Given this list of marker genes ZNRD2-DT, ZNF257, CCDC144A, MELTF, HOXA10, SIGLEC9, GNAQ, TFPI, ZSCAN16-AS1, GUSBP14, ECT2, CRNDE, LDC1P (NCBI Gene Id 651413), CHRNA3, IFT81, FCGR2C, ZBTB44, TIMM23B (translocase of inner mitochondrial membrane 23 homolog B), CCNJ, HPSE2, ADAMTS1, MDM4, CYP2F1, CUBN, SEM1, ETV5, PALLD, KIR2DL4, AEBP1, NEK2, DNAJC9, TNFRSF21, GPR4, CTTN, PTGDR2, NEIL3, ANP32A, CD79B, TCF7, COL6A3, HOXA7, GLI4, PCGF5, COL7A1, DST, HNRNPK, MARCKSL1, GARIN3, ITIH3, PELI2, SLC22A18AS, KIAA1217, RNFT2, RUBCNL, KMT2A, XCL1, SP4, LINC01686, DDX5, LAPTM4A, ENSG00000228919, ENSG00000257545, TTTY10, FAM118A, SOX4, CENPV, OPRPN, CORIN (corin, serine peptidase), CEP97, ANKRD36BP2, HOXA9, MSI2, SPCS2, SLC22A7, H2BW2, DLAT, IL4, DBN1, SIMC1P1, POMP, BATF3, RUFY2, TFF3, ANKRD20A11P, SORT1, INHBC, DNAI3, H3-3B, CHSY1, LRRN4, PPEF1, EVC2, BCL11B, OSBPL5, CDC25A, CCDC83, CALHM5, SH2D1A, KDM5D, FBLL1, RPS4Y1, LRRN1, TXLNGY, AKR1C3, KIF23, CBX5, SMPD3, QSER1, PDE10A, EPB41L2, ALDH2, ZNF169, ADGRB2, RGMA, ELAVL4, SYCE1 (NCBI Gene Id 93426), BMS1P20, SLC44A5, CD300A, FZD1, PRKY, PDZD9, PTGS1, MBD6, TRDMT1, LINC00205, CMC2, GPRIN1, KRTAP5-2, GGA1, HMGB3, LYST, DDX3Y, GJC1, PLCH1, CD1D, GLIPR1L1, GALNT2, CHD9, GXYLT2, RTN4, EIF1AY, LDLRAD3, GALNT7, PCMT1, WFDC3, ATP6AP1L (NCBI Gene Id 92270), CDK6, GNA15, UBE2J1, HHIP, LMO2, INPP5B, PKN2, PHLPP1, ITPRID2, CDSN, SLC7A3 (solute carrier family 7 member 3), TSPYL4, ANOS1, LILRA5, SEC14L4, EPM2AIP1, SPRED2, OR2F1, RAPGEFL1, TSPAN11, CFAP74, R3HDM2, USP9Y, YWHAQ, SLC7A11, CHRNA4, SERTAD4-AS1, ZBTB12, GAS7, PPM1D, CAPSL, GOT1L1, POU3F4, STS, DEPDC7, HTR2A, HNRNPA2B1, KIF20B, UBASH3B, PHACTR1, ZNF736, here is a description of the gene set: studied in species Homo sapiens Monocytes mature tom acrophages in the presence of the lineage determining cytokine M-CSF. They can be further polarized into M1 or M2 macrophages with distinct functional properties. We used microarrays to detail the global programme of gene expression underlying macrophage maturation and polarization and identified distinct classes of up-regulated genes during this process. from publication Martinez FO, Gordon S, Locati M, Mantovani A (PMID 17082649) Human Gene Set: GSE5099_CLASSICAL_M1_VS_ALTERNATIVE_M2_MACROPHAGE_DN Genes down-regulated in macrophages: classical (M1) versus alternative (M2).